The following is a description of a gene set: Mouse Gene Set: GOMF_HISTONE_UBIQUITIN_LIGASE_ACTIVITY Catalysis of the transfer of ubiquitin to a histone substrate. studied in species Mus musculus, and this is the list of marker genes: Rnf168, Dtx3l, Pcgf3, Uhrf1, Msl2, Huwe1, Rnf2, Trim37, Pcgf5 (NCBI Gene Id 78660), Rnf20, Ubr2